The following is a description of a gene set: studied in species Mus musculus Human Gene Set: CUI_TCF21_TARGETS_2_UP All significantly up-regulated genes in kidney glomeruli isolated from TCF21 knockout mice. from publication Cui S, Li C, Ema M, Weinstein J, Quaggin SE (PMID 16207825) Mouse mutations have provided tremendous insights into the molecular basis of renal and glomerular development. However, genes often play important roles during multiple stages of nephrogenesis, making it difficult to determine the role of a gene in a specific cell lineage such as the podocyte. Conditional gene targeting and chimeric analysis are two possible approaches to dissect the function of genes in specific cell populations. However, these are labor-intensive and costly and require the generation, validation, and analysis of additional transgenic lines. For overcoming these shortcomings and, specifically, for studying the role of gene function in developing glomeruli, a technique to isolate and purify glomeruli from murine embryos was developed. Combined with gene expression profiling, this method was used to identify differentially expressed genes in glomeruli from Pod1 knockout (KO) mice that die in the perinatal period with multiple renal defects. Glomeruli from early developing stages (late S-shape/early capillary loop) onward can be isolated successfully from wild-type and KO kidneys at 18.5 d postcoitus, and RNA can readily be obtained and used for genome-wide microarray analysis. With this approach, genes that are differently expressed between glomeruli from Pod1 KO and wild-type mice were identified, including a four-fold reduction of alpha 8 integrin mRNA in glomeruli from Pod1 KO mice that was confirmed by immunostaining. This procedure may be adapted to any transgenic strain, providing a rapid and efficient method to dissect the function of specific genes in glomerular development., and this is the list of marker genes: FKBP10, SELENOW, APCDD1, NFATC4, PTTG1, KNSTRN, GLRB, ESPL1, PALS2, DIPK1B, MAOA, LMNB1, ATP23, PRMT7, ASAP1, MAPKAPK3, FAP, SRL, XRCC1, TET1, COL6A1, RCN3, HS6ST2, KCP, COL8A2, MEG3, HUNK, EDNRA (NCBI Gene Id 1909), FAT3, LYPD6B, KRT18, STARD10, LSP1, NRP2, SUV39H1, KNL1, ARHGAP39, POSTN, SPC24, ECHDC2, RPSA, GJA1, TRPM4, MMP11, HELLS, MCM5, RELN, B4GALT2 (NCBI Gene Id 8704), SYNE2 (NCBI Gene Id 26075), SLC38A1, CDC25C, HOMER2, SLIT2, UHRF1, IGSF5, CKAP5, HOXB6, CDK2AP1, CCNA2, SGTA, MACROD1, CYBA, GATA6, PPAN, EYA1, MATN2, PRDX6, RHOU, TPX2, VASH2, MEIS1, PRIM1, CFTR, UTP15 (UTP15 small subunit processome component), KCND3, PDGFA, PA2G4, ADAMTS2, SEMA3C, PIN1, RRP1B, SALL2, THOP1, METTL1, COL1A1, CDCA8, PCDH8, MYCN, ADIPOR2, POLD1, CXXC4, EVC2, BMP5 (bone morphogenetic protein 5, NCBI Gene Id 653), EPHA4, MCM7, SOCS2, DGCR6, GNAS-AS1, TIMELESS, AR, VCAM1, CDKN1B, MRTO4, GALK1, RANBP1, NT5DC2, CYP7B1, NFIA, SOX11, CNDP2, MGP, CDC45, SIPA1L1, HNRNPU, PCBP4, TACC3, DCLK1, FYB1, IGSF8, CAPN6, IGFBP2, TSPAN33, ADAMTS20, ELP5, SKP2, RCC2, RHEBL1, TAF6L, SMC1A, COLEC11, MRPL9, MMP16, WNT4, NDUFB7, PYCR1, PARM1, APBB1, SKA3, FAXC, TBRG4, VPS37D, NPHP1, FRAS1, BCL7A, LGALS1, PATZ1, SRD5A1, HSPBP1, ATIC, LSM3, FCGRT, PFKL, MTMR7, UNC119, GREB1, FN1, NKD1, ZCCHC18, IGDCC4, PTN, BMP4, FMOD, SERTAD4 (NCBI Gene Id 56256), NOC4L, MORN2, UBE2C, BLM, SNRNP70 (small nuclear ribonucleoprotein U1 subunit 70), KCNT2, ASPM, GLI3, INCENP, DSCC1, TGFB3, NLGN2 (neuroligin 2), EMC8, CKS1B, KIF22, FBLN5, KRT8, CDK1, DTYMK, CLU (NCBI Gene Id 1191), ABHD16A, CCN4, PIMREG, PPA1, FKBP4, NCAPH2, DCAKD, PAPSS2, C1QL1, TMEM151B, LBP, CADPS2, STMN1 (NCBI Gene Id 3925), PSAT1, HJURP, FLYWCH1, NCAPH, MIF, PRDX2, UGT2B4, TTL, ACE2, KANTR, GPRASP2, NCAM1, YPEL1 (NCBI Gene Id 94021), CMC2, TRAPPC6A, HOXA11-AS, RAB17, CPNE5, IL33, BMPER, SLC7A2, FXN, DNAH1, PHGDH, PLCH1, DCTPP1, ANTXR1, GAS2L3, LAMA4, CA4, TEAD2, PLTP, HM13 (NCBI Gene Id 92622), MXD3, ZNRD2, OSCP1, ENTREP1, RTL6 (retrotransposon Gag like 6), AGTR2, UBE2T, CLCN2, VCAN, NR2F2, EXOSC5, DCN, PRNP, SNAP91, BNC2, CELSR1, ABHD14A, CENPX, LSM4, BOK, GRWD1, CDCA5, SNORD52, NME1, SNRPB, IQGAP3, GXYLT2, PAMR1, FNDC4, PDLIM4, CLEC11A, RFC3, NUF2, EFS, PIH1D1, BANF1, VPS72, ELAPOR1, SUMO3, PPP1R14B, GRIA3 (NCBI Gene Id 2892), ISLR, CLDN6, TCTN2, RNASEH2C, CDCA3, RELT, KNTC1, SESN2, CPXM1, ETV5, IGF1, HMMR, CENPK, ALDH16A1 (NCBI Gene Id 126133), ALCAM, RBFOX3, CCNB2, PCDH9, PRKAR1B, PTGDS, LUM, LRFN4, SELENOH, TGM2, CFH, CTHRC1, GAS6, LGI2, MIR17HG (miR-17-92a-1 cluster host gene), CDH6 (cadherin 6), CENPA, BZW2, CYP1B1, CELF4, NEURL1 (NCBI Gene Id 9148), ZMIZ1, CDCA7, MFAP2, ATP1A2, TMSB15B, RGS17, HDAC11, HLA-DMA, BEX1, SOAT1, RPS9, RBP1, MAP3K21, LRRC56, COMP, DTL, LHFPL2, RANGRF, MSI1, MDK, NFIX, CCDC80, PALM, SPINT1, SIX2, LAMA2, TYMS, TK1 (NCBI Gene Id 7083), ARSB, EMG1, GSTT2, SLC4A3, CD79B, FAM185A, CCND2, TNFAIP6, RNF227, HMGA2, RACK1, ATAD3A, TMEM238, CDT1, EPB41L4A, KCNK5, SRM, IPO13, SMCHD1, ECM1, AKR7A2, MEX3A, ZFPM2, TMEM231, PENK, MRPS27, KLF5, EXOSC8, MCM3, CBX5, PGAP2, SRPX (NCBI Gene Id 8406), CCDC88C, PAFAH1B3, MIR100HG, MNS1, SBK1, C1QTNF12, PAX8, ABHD11, FBLN7, FIRRM, ACTB, SYCE2, WFDC2, TMEM176B, TMEM132A, PLET1, RPL41, BRI3BP, SERPINF1, POLE3, RPL12, CD38, RAD51 (RAD51 recombinase), GRIP1, TGFBI, HMGB3, TIMM13, ZNF593, EEF1AKMT4, BOC, MISP, PYCR3, CDCA7L, COL6A2 (NCBI Gene Id 1292), ALDH18A1, POLD2, CLSTN2, GUK1, RAD18, ESR1, AMER2, LSR, HMGXB4, WNT8B, ZNF692, COL3A1, DYNC2I2, ANAPC15, CAD, ADCY2, CD276, CAMSAP3, CADM1, CHAF1B, APEX1, HNRNPR, SPON1, TMEM97, NSL1, CENPV, CLDN9, GPC6, SPSB4, ANKRD54, APRT, DNAJC9, PHACTR1, C19orf25, NIPSNAP1